Given this list of marker genes ESAM, SSH1, CAPZA3 (capping actin protein of muscle Z-line subunit alpha 3), CAPZA2, CRBN, FCHSD2, NAPA, CREB1, CARMIL1, TRIM65 (tripartite motif containing 65), MAPK9, GBA2, IL5, MYD88, CD36, HAUS3, TMOD1, EIF2AK2 (eukaryotic translation initiation factor 2 alpha kinase 2), RDX, SNCA, SPTBN1, RACK1, TOGARAM1, CLU, SYP, ATAT1, NME7, MAVS, FBXL2, HAUS5, PARK7, MTPN, HCFC1, SYK, ZDHHC1 (NCBI Gene Id 748), RASIP1 (Ras interacting protein 1), SEC16A, OCLN, CTTN, RB1, PAK3, IRGM, SPTBN2, PPP2R5B, LMOD1, PPP2CB, ABCA1, TRABD2B, FERMT1, FER, MPP7, PINK1, GBP2, NUMA1, ANKRD27, SAR1B, HAUS1, ULK1, MMP1, MECP2, OPRD1, TBCD, KIF14, EIF4G1, CCL24, MEFV, BIRC2, CDK5R1, TRAF3IP1, BAIAP2, STXBP5, AJUBA, PYDC1, ISG15, CSF3, PREB, LGALS3, BIK, BRSK1, SLF1 (SMC5-SMC6 complex localization factor 1), MSN, FCHSD1, NAPB, SOST, UNC13B, RAF1, DYRK1A, CRACD (capping protein inhibiting regulator of actin dynamics), TWF1, COTL1, CCR7, ARHGAP18, TMC8, KANK1, TREM2, SPTAN1, APOE (apolipoprotein E), GSN, TMSB4X, KCNK13, FSCN1, BCL11A, FNIP2, CFL1, VPS11, NCKAP1, CYRIB, PYDC5, SPTB, TRAF2, LMOD3, STMP1, HSPA8, BIN1, SLAIN2, CLIP3, AIDA, PIK3R2, ICE1, C15orf62, HRK (NCBI Gene Id 8739), RAP1B, MIR214, CCL21, TGFB1, PYDC2, ELN, VPS8, CAND1, STX1B, SKAP1, HAUS2, CARD8, NLRP2B, KIF9, GRB2, HCK, TP53 (NCBI Gene Id 7157), MMP3, CCL26, CSNK1A1, SNX9, SEPTIN8, STMN2, WASHC2C, MAPK15, USP50, NR1H2, SENP6, NCK2, VPS18, LCMT1, HAUS4, SH3GLB1, ABCA3, SSH2, TMOD3, BBS4 (NCBI Gene Id 585), EML2, MET, GFAP, SAR1A, PEX5, CDC42EP3, MED25, TPPP2, TFIP11, MIR144, FNIP1, ADD1, JAM3, SELP, RIOK3, MTLN, NLRC3, RICTOR, HSP90AA1, ARHGEF5, PYCARD, FBLIM1, MAPK8, GBA1, PAK1, VPS16, LATS1, BCL2L11, BRK1, TWF2, SLF2, DAAM2, VCP (NCBI Gene Id 94731), SVIL, SPTA1, BTK, RASA1, BAIAP2L1, BAK1, CDC42EP1 (NCBI Gene Id 129136), P2RX7, RPS3, SLIT2, CDC42EP2, ZNF827, SCIN, ALOX15, LATS2, MAP2, CAMSAP2, HAUS6, SRC, VPS39, CDC42, BBC3, HJURP, CLIP1, ABITRAM, NCLN, SSH3, PLCG2, STX1A, DCTN1, TRIM11, CAMSAP3, BBS10, BAIAP2L2, PPP2CA, TTBK1, MAPRE3, GSK3B, NOP53, TRIOBP, NCKAP1L, MARK4, LCAT, CDH17, PFN2, CPTP, BID, PTK2B, CTNNBIP1, ABL1, CSF2 (colony stimulating factor 2), PTGER4, CDH5, AKAIN1, CARMIL2, SPIDR, KIRREL1, CDK5RAP2, PRUNE1, ANKRD53, TPPP3, DRG1, HDAC6, PRKD1, PRKCZ (protein kinase C zeta), PTPN11, TFRC, MTOR, CDC42EP4, RPL13A, PLEKHG2, PIEZO1, RAC1, ARFGEF1, TMOD4, SORL1, ASB2, CRYAB, BAX, VASP, ATR, TICAM1, ARL2, LCP1, INPP5J, VPS41 (NCBI Gene Id 27072), EVL, TIRAP, RNF4, MAPT, TGFBRAP1, JMJD6, DHX33, CKAP5, FARP2, CDC42EP5, EPS8, GBP5, LRRK2, INSM1, TPPP, HSPA1A, ABHD17A (NCBI Gene Id 81926), MIR17, H3-3A, STXBP6, SYNGR3, CLEC7A, NAV3, SOX9 (SRY-box transcription factor 9), VILL, SLAIN1, AVIL, KIF21A, KCNK6, DKK1, ANKRA2, IFI16, ADD2, RALB, ISL1, TMOD2, MARCHF5, MYADM, CAPZB, CAMSAP1, STXBP1, HAX1, ARPC5L, VEGFA, GIT1, BRCC3, RHOA, PLEK, LMO4 (LIM domain only 4), HAUS8, DDX3X, NRG1 (NCBI Gene Id 653104), DLG1, ARF6, FERMT2, NCK1, HSPA1B, TNFSF18, HSPA5, ARPC3, SPTBN4, PRRT2, ATM, CXCL13 (NCBI Gene Id 115545), TRIM31 (tripartite motif containing 31), DACT1, MLST8, PFN1, CAV3, HCLS1, TRAPPC12, BAG4, SLC39A12, HIP1R, FKBP4, DAB2IP, THRA, RHOC, CYFIP1, CCL11, PDE4DIP, DNAJC6, LMOD2, PRKCE, NEK7, SVIP, PSRC1, SUMO1 (NCBI Gene Id 7341), ABHD8, CLASP1, ARPC5, P2RY12, TERF1, SIRT2, ZDHHC5, IKBKE (inhibitor of nuclear factor kappa B kinase subunit epsilon), DUT, CYRIA, TAL1, TUBB4A, KANK3, TLR6, CORO1A, DNAJC15, AMBRA1, STUB1, AKAP9, CLASP2 (NCBI Gene Id 440948), DMTN, VIL1, GNL3L, OGT, SKA1, STMN1, ZDHHC12, ARHGEF7, MAPRE1, MAP1B, VPS35, IAPP, HAUS7, CAPG, PREX1, FLII, PFN3, NPHS1, EP300, FES, KANK2, CAPZA1, ADD3, CYFIP2, TENM1, CDKN1B, WNT10B, HRG, HES1 (hes family bHLH transcription factor 1), UBLCP1, BMF, GAK, HSF1, LAMP2, PSMC6, HMGB1, SPTBN5, PTPN22, MKKS, H3-3B, TNF, IFNG, KANK4, WARS1, ARHGAP40, ARHGAP28, TRABD2A, PRKCD, OSBPL2, TLR4, VPS33A, ARPC2, here is a description of the gene set: Any process that modulates the frequency, rate or extent of protein complex assembly. studied in species Homo sapiens Human Gene Set: GOBP_REGULATION_OF_PROTEIN_CONTAINING_COMPLEX_ASSEMBLY